Given this list of marker genes HLA-C, TRIM21, TNFRSF11B, IFIT5, HES5, CCDC190, HLA-E, IFI16, KIR3DX1, LINC00623, RHOF, ZNF16, BST2, IFIT1, IRF9, PTRH2, OSR1, MGAT4C, DTX3L, CCDC144NL-AS1, KLK14, TREX2, TMEM186, KIF2B, IFITM2, SKP1, SHISA8, LRRC15, IFITM3, LYRM4-AS1, OAS3, ITPKB, ACTL7B, C5AR1, NAPA, CXorf51A, AGTRAP, CD47, DDX60L, THEMIS2, USP42, IFI35, ABHD2, FAM110B, PARP12, NOG, LY6E, HELZ2, COL11A2, PATE2, GNAL, SPMAP1, TNFRSF8, ODAPH, PPM1K, COL2A1, LHX4, COL25A1, TRIM13, ESPN, PARP14, BTN3A1, PROKR2, VWA3B, CCDC185, PRRG2, PML, PSME2, MEGF6, MYO7A, ATP5MK, PRX, PSME1, HNMT, LAMA3, DLG5-AS1, HPYR1, MYOF, SLC5A2, KDM3A, GLDC, ADAR, GMPR, LINC00658, LSR, TNFRSF4, RNF213, TUT7, MTERF4 (NCBI Gene Id 130916), CDH1, PLSCR1, H4C1, SLC22A24, DDX60, RBCK1, PARP9, DLGAP1-AS2, ISG15, LINGO1-AS1, THSD7B, TRIM25, HERC5, SCARA3, IFITM1, OVOL3, PROSER2-AS1, CMTM5, ROGDI, PIK3C2G, H19, TEX44, TBX5-AS1, SPINK1, IFI27, H2BC11, OR2F2 (NCBI Gene Id 402710), IFIT3 (NCBI Gene Id 8376), PTPN5, MYOCD, NRG2, SH3GL1P1, USP18, LINC00158, TWIST2, MAGEC2, CACNB2, BTN3A2, MOV10, JAML, KLHL3, ZNF831, COA7 (NCBI Gene Id 94485), MIR34BHG, SIRT5, SSR4P1, EPG5, EIF2AK2, SLC17A6, OAS1, IFI6 (NCBI Gene Id 2537), MMP10, SPATA17, CHCT1, DBP, ANO4, DAZL, KRT78, CMKLR1, ANGPT1, PHF11, UMODL1-AS1, ABCA1, P2RY6, TLK2 (NCBI Gene Id 11011), DLX1, STAT2, OASL, CMPK2, SPINK2, HAR1A, SP110, MINDY4, ZNF584, ADAM11, SLA2, RUNX1T1, HERC6, ZNRD2-DT, TRIM69, SLC28A3 (NCBI Gene Id 64078), JAZF1-AS1, RIGI, PPM1H, NKAPD1, TMEM200B, STAT1, DRAIC, ELL (NCBI Gene Id 84205), ZFP2, NLGN4Y, ANGPTL3 (NCBI Gene Id 54222), TDRD7, CNTN2, MAGEA4, IRF7, LGALS3BP, MIGA2, ARL3, BHLHE23, here is a description of the gene set: Genes up-regulated in double positive thymocytes with ELK1 and ELK4 knockout: untreated versus stimulated by anti-CD3. Human Gene Set: GSE21546_UNSTIM_VS_ANTI_CD3_STIM_SAP1A_KO_AND_ELK1_KO_DP_THYMOCYTES_UP from publication Costello P, Nicolas R, Willoughby J, Wasylyk B, Nordheim A, Treisman R (PMID 20554967) Removal of the transcription factor SAP1a member of the Ternary Complex Factor (TCF) group of transcription factors which in conjunction with Serum Response Factor (SRF) has been shown to have a profound effect on positive selection in the thymus. When another TCF Elk1 is knocked out in mice there is no effect on positive selection unless it is on a Sap1a KO background where the phenotype is very severe. We have stimulated isolated double positive T cells (DPs) with anti-CD3 to mimic positive selection and compared basal and stimulated transcription across the four genotypes to discover the downstream targets of Sap1a involved in positive selection. species: Homo sapiens